The following is a description of a gene set: Human Gene Set: GOBP_NEGATIVE_REGULATION_OF_VIRAL_TRANSCRIPTION Any process that stops, prevents, or reduces the frequency, rate or extent of viral transcription. studied in species Homo sapiens, and this is the list of marker genes: TRIM31, TRIM8, ZFP36, TRIM11, TRIM14, MID2, HEXIM1, TRIM32, LARP7, TRIM13, TRIM62, TRIM21, UBP1, TRIM27, IFITM3, SP100